The following is a description of a gene set: species: Homo sapiens Neighborhood of RBM8A Neighborhood of RBM8A RNA binding motif protein 8A in the MORF expression compendium Human Gene Set: MORF_RBM8A, and this is the list of marker genes: MOK, PITPNM1, PRPH, MPP2, USP19, SEMA4D, TCF7, PTPN9, ZKSCAN3, PAX8, PFDN1, ADAM15, IGSF9B, DMWD, TCOF1, AMELX, GPA33, DDX11, ZNF592, F7, TUB (NCBI Gene Id 7275), MAG, HSF4, PIGB, TRA2A, SLC22A24, SLC5A2, HAUS5, TNP1, SLC12A4, PCBP3, IGHMBP2, TSPO2 (translocator protein 2), PTGER3, ZBED1, PRSS16, KHNYN, HMGXB3, SLC6A9, GSK3A, TPMT, DGCR11, CAMK2B, LTK, FDXR, MVK, IFT140, ADAMTSL2, EPOR, ACR, CASP2, RBM8A, LSM12, ODF1, CRCP, NUDT3, CARD10, ANKRD12 (ankyrin repeat domain 12), CDK5R1, ITGAD, MMP25, GPRIN2, LMTK2 (lemur tyrosine kinase 2), CNOT4, TMEM94, MC2R, RBBP8, MYL2, NTSR2, TAGLN3, GHITM, PNMT, HTR2A, ENTREP1, GPR161, PMF1, PKN2, EML3, PML, H6PD, IKBKG, NTNG1, FKBP15, HSPB2, CNTN1